Given this list of marker genes Gna12, Gna14, Gng11, Gngt2, F2, Gng5, Arrb2, Mapk3, Gng8, Gnb2, Gna13, Gng7, Gngt1, Gnb5, Gnb3 (guanine nucleotide binding protein (G protein), beta 3), Gng3, Gng4, Gng10, F2rl3, here is a description of the gene set: Reactome Pathway: Thrombin signalling through proteinase activated receptors (PARs) part of: Platelet activation, signaling and aggregation This event has been computationally inferred from an event that has been demonstrated in another species.<p>The inference is based on the homology mapping from PANTHER. Briefly, reactions for which all involved PhysicalEntities (in input, output and catalyst) have a mapped orthologue/paralogue (for complexes at least 75% of components must have a mapping) are inferred to the other species. species: Mus musculus electronically inferred by orthology from the curated human pathway